Given this list of marker genes TNNI2, DPH1, PEX11B, FGFR2, CHST3, TWIST1, BRD4, PEX13, PEX1, HDAC4, PEX10, ROR2, EXT1, NALCN (NCBI Gene Id 93074), PEX26, TPM2, RAD21, NECTIN1, PEX19, SMC3, NOG, TSEN2, TRPS1, TAF6, GDF5, HDAC8, FGFR3, CD96, TAF4, MYH3, PEX3, PEX2, PEPD, NUP188, TNNT3, SMOC1, TELO2, TSEN34, CDK10, FIG4, SEPSECS, NIPBL, PEX14, TSEN54, PEX6, PEX12, TSEN15, TBX4, CKAP2L, NXN, SMC1A, BMPR1B, DIS3L2, PNPLA6, ESCO2, KAT6B, FGF9, CCBE1, PEX5, RNU4ATAC, PTPRF, DPH2, PEX16, SMAD2, here is a description of the gene set: The distal and proximal transverse palmar creases are merged into a single transverse palmar crease on both hands. Bilateral single transverse palmar creases species: Homo sapiens Human Gene Set: HP_BILATERAL_SINGLE_TRANSVERSE_PALMAR_CREASES